The following is a description of a gene set: studied in species Mus musculus A P granule that contains the PIWIL4-TDRD9 module, a set of proteins that act in the secondary piRNA pathway. Mouse Gene Set: GOCC_PIP_BODY, and this is the list of marker genes: Mael, Ddx4, Tdrd9 (NCBI Gene Id 74691), Piwil4, Gtsf1, Tdrkh